Given this list of marker genes FGFR1, ESRRG, CTTN, FGF3, SOX9, ERBB2, STK3, TG, WNT3, EBAG9 (NCBI Gene Id 9166), KCNQ3, MYC, RBBP5, JAG1, WNT9B, PAK1 (p21 (RAC1) activated kinase 1), BCL6, CCND1, MTSS1, PTPRT, PREX1, EXT1, SLA (NCBI Gene Id 6503), here is a description of the gene set: Genes from the most frequent genomic gains and amplifications in a panel of patients with lymph node negative breast cancer (NNBC). Human Gene Set: CLIMENT_BREAST_CANCER_COPY_NUMBER_UP Despite the recent consensus on the eligibility of adjuvant systemic therapy in patients with lymph node-negative breast cancer (NNBC) based on clinicopathologic criteria, specific biological markers are needed to predict sensitivity to the different available therapeutic options. We examined the feasibility of developing a genomic predictor of chemotherapy response and recurrence risk in 185 patients with NNBC using assembled arrays containing 2,460 bacterial artificial chromosome clones for scanning the genome for DNA copy number changes. After surgery, 90 patients received anthracycline-based chemotherapy, whereas 95 did not. Tamoxifen was administered to patients with hormone receptor-positive tumors. The association of genomic and clinicopathologic data and outcome was computed using Cox proportional hazard models and multiple testing adjustment procedures. Analysis of NNBC genomes revealed a common genomic signature. Specific DNA copy number aberrations were associated with hormonal receptor status, but not with other clinicopathologic variables. In patients treated with chemotherapy, none of the genomic changes were significantly correlated with recurrence. In patients not receiving chemotherapy, deletion of eight bacterial artificial chromosome clones clustered to chromosome 11q was independently associated with relapse (disease-free survival at 10 years+/-SE, 40%+/-14% versus 86%+/-6%; P<0.0001). The 54 patients with deletion of 11q (29%) did not present more aggressive clinicopathologic features than those without 11q loss. The adverse influence of 11q deletion on clinical outcome was confirmed in an independent validation series of 88 patients with NNBC. Our data suggests that patients with NNBC with the 11q deletion might benefit from anthracycline-based chemotherapy despite other clinical, pathologic, or genetic features. However, these initial findings should be evaluated in randomized clinical trials. species: Homo sapiens from publication Climent J, Dimitrow P, Fridlyand J, Palacios J, Siebert R, Albertson DG, Gray JW, Pinkel D, Lluch A, Martinez-Climent JA (PMID 17234794)